Given this list of marker genes PHKB, SNORD115-1 (small nucleolar RNA, C/D box 115-1), MSH5, MKRN3, PHKG2, BSCL2, TP53, PWRN1, FOXL2, FOS, FANCM, CAVIN1, GNAS, MAGEL2 (NCBI Gene Id 54551), STUB1, NPAP1, CISD2, PLIN1, SYCP2L, RNF216, AKT2, LIPE, H6PD, CAV1 (caveolin 1), AGPAT2, NR3C1, SNORD116-1, CDH23, BRAF, PHKA2, MEIOB, GALT, PWAR1, ERCC6, FSHB, USP8, PRLR, LHB, LARS2, PPARG, GPR101, AIP, HERC2, ATRX, USP48, CIDEC, TPR, here is a description of the gene set: species: Homo sapiens Infrequent menses (less than 6 per year or more than 35 days between cycles). Human Gene Set: HP_OLIGOMENORRHEA Oligomenorrhea